Given this list of marker genes P4HB, ERO1B, ERO1A, QSOX1, QSOX2, GFER, here is a description of the gene set: Human Gene Set: GOMF_THIOL_OXIDASE_ACTIVITY species: Homo sapiens Catalysis of the reaction: 2 R'C(R)SH + O2 = R'C(R)S-S(R)CR' + 2 H2O2.